Given this list of marker genes Sos1, Ugt2a3, Cadm2, Chrna3, Nkain2, Ercc6l, Tead1, Trim27, G2e3, Mcur1, Nxf1, Prps2, Plscr1l1, Bicd1, Eif4e, Six6, Tet2, Ifih1, Mfap3l, Pate9, Ndnf, Vmn1r71, Astn2, Ate1, Surf2, Tent5c, Plpp3, Scml2, Sohlh2, Zeb2, Pip4p2, Pgap6, Aste1, Myrip, Dcun1d2, Zbtb11, Cenpi, Tmem39a, Prg4, Acer3, here is a description of the gene set: Genes predicted to be targets of miRBase v22 microRNA mmu_miR_1941_3p in miRDB v6.0 with MirTarget v4 prediction scores > 80 (high confidence targets). studied in species Mus musculus Mouse Gene Set: MIR_1941_3P from publication Chen Y, Wang X (PMID 31504780)